The following is a description of a gene set: Hydroxyprolinuria Human Gene Set: HP_HYDROXYPROLINURIA species: Homo sapiens An increased concentration of 4-hydroxy-L-proline in the urine., and this is the list of marker genes: TNFRSF11A, PRODH, PLOD2, SLC6A19, TNFRSF11B, ALDH4A1, SLC6A18, SLC36A2, SLC6A20